The following is a description of a gene set: studied in species Mus musculus Binding to an estrogen response element (ERE), a conserved sequence found in the promoters of genes whose expression is regulated in response to estrogen. Mouse Gene Set: GOMF_ESTROGEN_RESPONSE_ELEMENT_BINDING, and this is the list of marker genes: Ar, Pgr, Esrrg, Nr6a1, Esr2 (NCBI Gene Id 13983), Esrra, Esr1, Nr3c1, Esrrb (estrogen related receptor, beta), Nr3c2, Trim24